Given this list of marker genes Rab34, Spg11, Cln3, Syt7, Rab7b, Rab39, Pla2g5, Rab7, Rab20, Arl8b, Tmem175 (NCBI Gene Id 72392), Pikfyve, here is a description of the gene set: studied in species Mus musculus Mouse Gene Set: GOBP_PHAGOSOME_LYSOSOME_FUSION The creation of a phagolysosome from a phagosome and a lysosome.